Given this list of marker genes COL4A2, SYNGR2, ELK1, CD63, PPID, BRCA2, GALT, CTSF, TFRC, CST5, MDM2, MAN2A2, PLA2G4A, RPL13A, IFRD2, FXN, ASCL2, CASP8, HSD11B2, ID2, FECH, CR2, NRAS, ACHE, POLD2, HIF1A, FUT1, BAX, RNASEH2A, ENO1, CLNS1A, ATP1A2, APP, EIF5A2, ARF1, NR1D1, VHL (NCBI Gene Id 8056), SLC19A1, MCL1, ID3, GSK3B, SERPINE1, COL4A1, HMOX1, RBM3 (RNA binding motif protein 3), RARA (NCBI Gene Id 5914), POLB, STMN1, HSPA8, HSPD1, ACAD10, TGFB3, PEX3, LBR, DKC1, PTEN, ACP3, PTMA, TGFB2, EPB42, RPL19, NIT1, AKR1A1, CXCL2, INSR, IRF2, TERT, GSTP1, MET, SLC2A4 (NCBI Gene Id 6517), MYBL2, JUNB, EIF4A1, MUC1, FGFR4, CEBPA, BSG, IRF3, AKAP1, ITGB1, HNRNPA2B1, RPS6, TGFBR1, CASP9, MSN, SLC4A2, APC, ACO2, CFDP1, SRD5A1 (NCBI Gene Id 6715), TCF12, SLBP, IL11RA, IL13, UCP3, HMBS, ACADM, PRKDC, NTHL1, MEN1, ATF4, IL2, INSM1, RPL22, RABGAP1L, PPP1R7, CCKBR, JUN, PAICS, NAB2, LTB (NCBI Gene Id 4050), QDPR, AMD1, UBA52, CD79B, HNRNPDL, ID2B, GPR4, E2F1 (NCBI Gene Id 1869), NME1, FPGS, CLCN6, ARF4 (ADP ribosylation factor 4), PER1, CLDND1, ACOX1, AHSG (NCBI Gene Id 780898), GAL, PSMB1, BCL3, OCA2 (OCA2 melanosomal transmembrane protein), PRTN3, ICAM1, HNRNPA1, PKP1, VAMP2, HMGN2 (high mobility group nucleosomal binding domain 2), WT1, EPHX1, ACTG1, NTN3, TPM2, PHB1, RPL27A, HERPUD1 (NCBI Gene Id 9709), AEBP1, NEFM, THRA, ALDH2, ETS2, HSPE1, LMNA, EIF4E, NBN, SIM2, NHERF2, FOXM1, TXN, STAT6, TOP1, AMPD3, BBC3, TGFB1, HOXD13, DCK, MPO, CSTB, TCIRG1, ZNF146, MAGEA3, IMPA2, CHRNB1, PI3, UCP1, MCM7, PDHA1, CEACAM5, BCL2, ISG20, UROD, ITGA6, here is a description of the gene set: species: Homo sapiens from publication Fernandez PC, Frank SR, Wang L, Schroeder M, Liu S, Greene J, Cocito A, Amati B (PMID 12695333) The transcription factor Myc is induced by mitogenic signals and regulates downstream cellular responses. If overexpressed, Myc promotes malignant transformation. Myc modulates expression of diverse genes in experimental systems, but few are proven direct targets. Here, we present a large-scale screen for genomic Myc-binding sites in live human cells. We used bioinformatics to select consensus DNA elements (CACGTG or E-boxes) situated in the 5' regulatory region of genes and measured Myc binding to those sequences in vivo by quantitative chromatin immunoprecipitation. Strikingly, most promoter-associated E-boxes showed selective recovery with Myc, unlike non-E-box promoters or E-boxes in bulk genomic DNA. Promoter E-boxes were distributed in two groups bound by Myc at distinct frequencies. The high-affinity group included an estimated 11% of all cellular loci, was highly conserved among different cells, and was bound independently of Myc expression levels. Overexpressed Myc associated at increased frequency with low-affinity targets and, at extreme levels, also with other sequences, suggesting that some binding was not sequence-specific. The strongest DNA-sequence parameter defining high-affinity targets was the location of E-boxes within CpG islands, correlating with an open, preacetylated state of chromatin. Myc further enhanced histone acetylation, with or without accompanying induction of mRNA expression. Our findings point to a high regulatory and biological diversity among Myc-target genes. Genes identified by ChIP within the high-affinity group of MYC targets. Human Gene Set: FERNANDEZ_BOUND_BY_MYC